The following is a description of a gene set: species: Homo sapiens Genes down-regulated in comparison of B cells versus myeloid dendritic cells (mDC). Systems vaccinology has emerged as an interdisciplinary field that combines systems wide measurements and network and predictive modeling applied to vaccinology. Here we used the systems vaccinology approach to study the molecular mechanisms underlying th Human Gene Set: GSE29618_BCELL_VS_MDC_DN from publication Nakaya HI, Wrammert J, Lee EK, Racioppi L, Marie-Kunze S, Haining WN, Means AR, Kasturi SP, Khan N, Li GM, McCausland M, Kanchan V, Kokko KE, Li S, Elbein R, Mehta AK, Aderem A, Subbarao K, Ahmed R, Pulendran B (PMID 21743478), and this is the list of marker genes: PRKAR1A, GRSF1, ARPC2 (actin related protein 2/3 complex subunit 2), ASAP1, PRCP, APAF1, S100A4, TRIB1, CORO1A, MYL6, ARRB1, SELPLG, CD1E, DDIT4, NIBAN1, RAB11FIP1, ARPC4, ATP6AP1, NUP93, SEPTIN2, KCTD12, RBPJ, CD1D, ETS2, CEBPD, FZD1, ARL4C, WDR1, UQCRFS1, CTSH, CSF3R, RHOG, SEMA4A, CD63, IMPA2, DPYSL2, CTSB, GLIPR1, COTL1, MYOF, SYNGR2, BATF3, DDOST (NCBI Gene Id 1650), SCD, CDK2AP1, CCDC88A, ENO1, PLBD1, HLA-DRA, RTN1, GNG5, TGFBI, SPATS2L, ST3GAL6, EFHD2, EIF4A1, FLT3, NDUFA6, IPCEF1 (interaction protein for cytohesin exchange factors 1), RAB31, RAP2B, MACROH2A1 (NCBI Gene Id 9555), ILK, LMNA (lamin A/C), IL18, ITGB2, DUSP3, OTULINL, RGS1, LY75, STOM, ITPK1 (NCBI Gene Id 3705), IL18R1, RAB32, NDFIP1, TUBA1B, TMSB10, ACTG1, DST, CALM2 (calmodulin 2), CKLF, CCR5, IGFBP7, RNF130, NDRG2, ATP6AP2, PADI2, LAMTOR2, PTTG1IP, VIM, MYDGF, ARPC1B, FYB1, RAB7A, DPYD, PICALM, CSTB, C1orf54, CAP1, CANX, LCP1, CAPZA2, TIMP1, CD101, ANXA2, RPS6KA4, PEA15, MBOAT7, AHR, NAGA, MYL12A, SEZ6L, GSTO1, FKBP1A, LMO2, CYFIP1, GRN, UBE2L3, SHTN1, RGS10, AXL (NCBI Gene Id 558), TUBA1C, PKM, APMAP, SH3BP4, IL13RA1 (NCBI Gene Id 3597), LGALS1, ATG3 (autophagy related 3), CD93 (CD93 molecule), GLRX, RTN4, COX8A, ACAA1, FCER1A, GNAI2, TXN, MAP2K1, GSN (gelsolin), SEC13, APOBR, MRTFA, ITGAX, CPT1A, TIPARP, NREP, PLEKHO1, SPINT2, GMFG, PAK1, TOB1, NDRG1, ARPC5, CPPED1, IFI30, CAT, IL6R, ID2, CD33, PFN1, SKIC8, CST3, GBE1, FBP1, LSP1, NUDT3, ATP1B1, ACTB, RCAN1, CLIC2, SSR1, CD1C, AP1S2, RFK, CUEDC2 (NCBI Gene Id 79004), CLEC10A, NDUFA4, S100A10, RRBP1, PSTPIP2, CCT6A, ANXA5, PTGS2, S100A6, SEC11A, TPP1, GABARAP, SLC30A1, PYCARD, DAB2, HOXA9, BHLHE40, GAPDH, ADAM8, GSTP1, CAPG, GNAQ, KLF4, PPIF, CASP1, F11R